Given this list of marker genes ATP6V0C, GCSH, CDKL5, SLC13A5, DEPDC5, NECAP1, WARS2 (NCBI Gene Id 10352), PIGS, GALNT2, TANGO2 (NCBI Gene Id 128989), ATP1A3, TBCK, ARV1, BRAT1, ADPRS, SMC1A, CARS2, TFE3, FRRS1L, DNM1, PIGQ, PPP2R5D, here is a description of the gene set: Human Gene Set: HP_MULTIFOCAL_SEIZURES Multifocal seizures species: Homo sapiens Seizures that start from several different areas of the brain (i.e., with multiple ictal onset locations).